The following is a description of a gene set: species: Mus musculus part of: MAP kinase activation electronically inferred by orthology from the curated human pathway This event has been computationally inferred from an event that has been demonstrated in another species.<p>The inference is based on the homology mapping from PANTHER. Briefly, reactions for which all involved PhysicalEntities (in input, output and catalyst) have a mapped orthologue/paralogue (for complexes at least 75% of components must have a mapping) are inferred to the other species. Reactome Pathway: MAPK targets/ Nuclear events mediated by MAP kinases, and this is the list of marker genes: Mapk8, Ppp2r1b, Rps6ka5, Mapk9, Dusp7, Ppp2r5d, Fos, Jun, Mapk11, Vrk3, Dusp6 (NCBI Gene Id 67603), Mapk7, Mapk3, Mapk14